The following is a description of a gene set: Mouse Gene Set: GOBP_NEGATIVE_REGULATION_OF_FIBRINOLYSIS species: Mus musculus Any process that stops, prevents, or reduces the frequency, rate or extent of fibrinolysis, an ongoing process that solubilizes fibrin, resulting in the removal of small blood clots., and this is the list of marker genes: Hrg, Vtn, Cpb2, Thbs1, Plat, Apoh, Plg, Plau, Serpine1, Serpinf2